The following is a description of a gene set: Evagination of the presynaptic membrane, resulting in the formation of a new synaptic vesicle. Human Gene Set: GOBP_SYNAPTIC_VESICLE_BUDDING_FROM_PRESYNAPTIC_ENDOCYTIC_ZONE_MEMBRANE species: Homo sapiens, and this is the list of marker genes: DNM1, MX1, DNM2, MX2, AP3D1, SLC2A4, DNM3, AP3S1, AP3B2, AP3M2, AP3S2